The following is a description of a gene set: Absence (due to failure to form) or underdevelopment of the humerus. Aplasia/hypoplasia of the humerus species: Homo sapiens Human Gene Set: HP_APLASIA_HYPOPLASIA_OF_THE_HUMERUS, and this is the list of marker genes: FLNB, POLR3A, FANCB, ESCO2, TBX5, GNPNAT1 (glucosamine-phosphate N-acetyltransferase 1), TNFRSF11B, LONP1, PEX5, AGPS, ZIC3, SUCLG1, IHH, ATP7A, RBM8A, CCN2, TGDS, GPC6, MTHFS, RNU4ATAC, NOG, MYSM1, RECQL4, GNPAT, GDF5, KIAA0753, FZD2, FLNA, GSC, IFT122, SNRPB, LMBR1, ALG12, TBX3, SALL4